The following is a description of a gene set: Genes down-regulated in comparison of B cells versus neutrophils. from publication Konuma T, Nakamura S, Miyagi S, Negishi M, Chiba T, Oguro H, Yuan J, Mochizuki-Kashio M, Ichikawa H, Miyoshi H, Vidal M, Iwama A (PMID 21540074) species: Homo sapiens Each fraction of mouse hematopoietic cells was purified by cell sorting from bone marrow of 8-week-old C57BL/6 mice, and its gene expression was analyzed. Human Gene Set: GSE27786_BCELL_VS_NEUTROPHIL_DN, and this is the list of marker genes: SREBF2, NSDHL, CYP2C18, ASPHD1, NPTXR (NCBI Gene Id 23467), RALA, GP9, ARHGEF7, IFT81, CORO1C, HMGB2, DRC12, CRHR2, FAM114A1, FOXN2, GLUD1, STK36, TRIP12, TNFRSF1B, NUDT13, FNDC8, CCDC88C, CHIA, HLX, ITM2C, MAP7D1, ZIM2, ROCK1, MYBPC1, TULP2, IGF2R, PABIR1, GAK, EFHB, CLEC10A, SH3BP2, SLC25A34, CSNK2B, TAX1BP1, SHISAL2B, FNDC1 (NCBI Gene Id 84624), AXL, FBXW12, LXN, PRAMEF12, ABCC6, NAA35, ARL2BP, SCAMP2, CITED2, DZIP1, SLC37A3, TMUB2, TEX2, FOXRED2, AMIGO1, PRKRA, SGK3, GPC1, TMEM120A, STK39, ATXN1L, HOXA9, VTI1B, KLRG1, CYP26A1, AMOTL2, CRX, CD244, HBP1, UBE2L6, ID2, CDC42EP5, BET1L, OSBPL7, UNC5B, ACOX2 (NCBI Gene Id 8309), PLPPR2, VN1R5 (NCBI Gene Id 317705), ATP6V1C2, SIX6, SNED1, PDCD6, IFIT1B, COX8A, BOC, CFP, PRKCH, SERINC2, EXTL2, HSD17B14, IL5, ELOVL1, COPZ2, NPY, TMEM9B, COMMD1, CHRM3, ENO1, GALE, ARMC3, CNIH4, ITGAL, LRRC36, PRC1, GRHL2, UBD, FADS3, PALS1, GUCY2C, S100A1, BIK, FBXO42, TMEM30A, MTMR3, HOXD4, H2AJ, BRK1, PCYT1A, SSC4D, PAG1, PCOLCE, ASB6, FGF21, ATP8A2, SLN, GOLM1, C2orf68, DGCR6, SLC17A9, UFD1, ITPK1, ADAMTSL3, COL11A2, SERF2, RTP4, KLHL12, ATP2B2, GJA4, GTF2IRD1, ULK1, POMT2, SPARCL1, HOXA7, BCORL1, MASTL, SFMBT2, BATF2, GDF9, CIMIP2A, CTNNA2, CEL, MMRN2, FNIP2, ARID3A, PRUNE1 (prune exopolyphosphatase 1), ENPP2, RIMKLA, TFAP2B, RAD54B, GARIN3, CPA1, CLEC12B, RAD51B, AKNA, RAP2B, KLK10 (kallikrein related peptidase 10), ATG5, PKD2, C10orf90, SPATA21, FBXO3, FBXO34, KNDC1, SNORD89, PRKAR2A, SERPINB6, PXMP2, MUC4, HK1, EVC2, ANKRD63, SELP, PTGFR, MAEA, GPX4, ATOH7, CD4, CPN1, BAIAP3, BBOX1, FUT2, KIF7, GPR153, PPOX, NRG2, CDK14, RCSD1, RAP1B